Given this list of marker genes TSPOAP1, RAN, LRP2, HSD17B7 (hydroxysteroid 17-beta dehydrogenase 7), HSD17B3, DHCR7, CYP11B2, UBE2I, NSDHL, MVK, FDXR, MBTPS1, CYP8B1, LHB, CYP2R1, STARD3NL, CYP11B1, AKR1C1, CREBBP, PMVK, NCOA2, CH25H, ACACB, HSD17B2 (hydroxysteroid 17-beta dehydrogenase 2), TBL1XR1 (NCBI Gene Id 81612), HSD17B14 (NCBI Gene Id 51171), MED1, HSD3B2, AMACR (alpha-methylacyl-CoA racemase), MBTPS2, PPARA, TGS1, SUMO2 (small ubiquitin like modifier 2), LGMN, CUBN (NCBI Gene Id 8029), OSBPL1A, HSD3B1, STARD5, CARM1, FDX1, TM7SF2, FDX2, FDPS, SRD5A3, GC, STARD4, CYP11A1, GPAM, OSBPL7, CYP39A1, PLPP6, ABCB11, LSS, SLC27A2 (solute carrier family 27 member 2), SLCO1A2, ARV1, TSPO, CYP46A1, HSD11B2, CYP7B1 (NCBI Gene Id 9420), AKR1C3, ABCC3, CYP17A1, STAR, CYP27B1, POMC, GGPS1, LBR, CYP27A1, SLC10A1, NCOA1, NCOA6, SC5D, IDI1, INSIG2, SRD5A1, ACACA, SEC24D, BAAT, OSBPL9, STS, HSD17B12, CYP51A1, SLCO1B1, HSD17B4, CYP24A1, SCD, HMGCR, SP1, ALB, SEC24B, TBL1X, OSBPL3, CYP21A2, SLC27A5, NFYB, CYP19A1, NFYA, SCAP, SQLE, SCP2, HSD3B7, OSBPL2, INSIG1, SREBF2, AKR1C4, ELOVL6, ACAT2, SEC23A, SRD5A2, VDR, STARD3, ACOT8, CGA, HSD17B11, SEC24A, IDI2, MVD, SREBF1, PIAS4, SLC51B, HELZ2, MTF1, SERPINA6, LDLRAP1, SMARCD3, EBP, ACOX2, CHD9, SLC51A, AKR1C2, AKR1B1 (aldo-keto reductase family 1 member B), FABP6, AKR1D1, STARD6, SLCO1B3, NFYC, SLC10A2, HSD11B1, CYP7A1, MSMO1, DHCR24, RXRA, FASN, HSD17B1, HMGCS1, AKR1B15, OSBP, OSBPL6, FDFT1, KPNB1, SAR1B, NR1H4, SEC24C, here is a description of the gene set: studied in species Homo sapiens Human Gene Set: REACTOME_METABOLISM_OF_STEROIDS Metabolism of steroids